Given this list of marker genes Nhlh1, Cntnap2, Fgf23, Atp1a2, Myo1f, Usp37, Or6b2, Fut7, Clstn3, Myl2, Kcnip3, Lrcol1, Btbd17, Ccdc187, G6pc1, Rnf224, Cibar2, Sp7, Slc45a3, Gja5, Car15, Il17re, Stra6, Slc16a8, Entpd8, Slc17a7, B230206H07Rik, Abcg8 (NCBI Gene Id 67470, ATP binding cassette subfamily G member 8), Prnd, Wfdc21, Adamtsl2, Slc4a1, Rgs14, Nr0b2, Gm4792, AU021092 (NCBI Gene Id 385603), Kiss1, Slc13a2, Ntng2, Krtap5-4, Cdh7, Prr15l, Prss34, Eppin, Zfp385c, Mrgprg, Trpm2, Tnfrsf9, Txndc8, Cdhr2, Abcg5, Htr3b, Pdzk1ip1, Sost, Fndc8, Septin12, Lhx4, Cd207, Mmel1, Pax4 (NCBI Gene Id 18506), Plcd4, Card14, Gucy2f (guanylate cyclase 2f), Hdc, Btnl9, Ccm2l, Rd3, Hapln2, Sp6 (NCBI Gene Id 83395), Or9s14, Pklr, Plcb2, Wfdc17, Lcn8, Ppy, Btnl10, Adamts13, here is a description of the gene set: Mouse Gene Set: MIKKELSEN_MEF_LCP_WITH_H3K27ME3 studied in species Mus musculus from publication Mikkelsen TS, Hanna J, Zhang X, Ku M, Wernig M, Schorderet P, Bernstein BE, Jaenisch R, Lander ES, Meissner A (PMID 18509334) Genes with low-CpG-density promoters (LCP) bearing the tri-methylation mark at H3K27 (H3K27me3) in MEF cells (embryonic fibroblasts). Somatic cells can be reprogrammed to a pluripotent state through the ectopic expression of defined transcription factors. Understanding the mechanism and kinetics of this transformation may shed light on the nature of developmental potency and suggest strategies with improved efficiency or safety. Here we report an integrative genomic analysis of reprogramming of mouse fibroblasts and B lymphocytes. Lineage-committed cells show a complex response to the ectopic expression involving induction of genes downstream of individual reprogramming factors. Fully reprogrammed cells show gene expression and epigenetic states that are highly similar to embryonic stem cells. In contrast, stable partially reprogrammed cell lines show reactivation of a distinctive subset of stem-cell-related genes, incomplete repression of lineage-specifying transcription factors, and DNA hypermethylation at pluripotency-related loci. These observations suggest that some cells may become trapped in partially reprogrammed states owing to incomplete repression of transcription factors, and that DNA de-methylation is an inefficient step in the transition to pluripotency. We demonstrate that RNA inhibition of transcription factors can facilitate reprogramming, and that treatment with DNA methyltransferase inhibitors can improve the overall efficiency of the reprogramming process.